The following is a description of a gene set: Mouse Gene Set: GOBP_SODIUM_ION_TRANSMEMBRANE_TRANSPORT A process in which a sodium ion is transported from one side of a membrane to the other by means of some agent such as a transporter or pore. studied in species Mus musculus, and this is the list of marker genes: Scn2a, Wnk1, Kcnq1, Slc24a2, Slc6a19, Slc9a9, Kcnq2, Snta1, Slc6a6, Atp2b4, Slc4a8, Slc9a3, Slc9b2, Slc20a1, Trpm2, Kcnk9, Slc6a12, Cnga3 (NCBI Gene Id 12790), Scn4b, Atp1b1, Slc6a8, Slc24a3, Scn7a, Grin1, Asic3, Slc6a16, Cftr, Slc6a15, Hcn3, Scn3b, Slc6a3, Slc4a4, Slc5a4b, Slc41a1, Mcoln3, Slc34a3, Slc6a20a, Slc9a6, P2rx7, Atp4a, Slc12a3, Atp1a2, Nedd4l, Tesc, Scn4a, Scn1b, Nppa, Commd1, Cav3, Slc5a1, Nherf1, Tpcn2, Slc4a10, Slc5a3, Atp12a, Scn10a, Slc24a1, Slc9a4, Slc9a2, Atp1a3, Fgf13, Scnn1b, Slc5a4a, Slc41a3, Scn11a, Trpm5, Slc8b1, Slmap, Trpv3 (transient receptor potential cation channel, subfamily V, member 3, NCBI Gene Id 68700), Tpcn1, Hcn2, Slc6a1, Neto1, Tescl, Slc24a5, Ptpn3, Slc13a5, Slc6a2, Pcsk9, Slc20a2, Slc28a3, Slc38a4, Scn8a, Kcnk3, Fxyd4, Slc23a1, Slc6a21 (solute carrier family 6 member 21), Slc5a6, Wnk2, Gpd1l (NCBI Gene Id 72363), Asic1, Slc8a3, Slc9a8, Cnksr3, Atp1a1, Slc6a9, Fxyd1, Camk2d (calcium/calmodulin-dependent protein kinase II, delta), Grin2a, Cnnm4, Chp1, Rangrf, Slc6a20b, Bpifa1, Slc13a2, Nalcn, Mcoln1, Slc38a5, Slc17a8, Nos1, Slc4a7, Fxyd7, Slc9a7, Wnk4, Asic2, Slc6a17, Atp1b2, Slc8a2, Fxyd5, Bpifa5, Slc6a7, Asic4, Slc38a2, Slc6a5, Pkd2, Fxyd6, Fgf12, Agrn, Slc9a1, Scn5a, Cnga1, Slc17a7, Trpm4, Slc12a2, Slc6a14, Nedd4, Slc6a11 (NCBI Gene Id 78727), Slc8a1 (solute carrier family 8 (sodium/calcium exchanger), member 1), Hcn4, Fxyd2, Slc12a1, Plcb1, Hcn1, Prss8, Slc34a1, Ank3, Asic5, Gm13629, Scn2b, Scn9a, Slc4a11, Slc5a2, Dmd, Slc9a5, Scn3a, Ano6, Fxyd3, Arf1, Slc17a6, Slc4a5, Scn1a, Pkd2l1, Scnn1g, Atp1b3, Drd4, Slc6a4, Scnn1a, Slc6a18, Tmem168, Slc34a2, Slc38a1, Grp, Slc24a4, Slc9c1, Slc13a1, Ywhah, Atp1a4, Slc4a9, Osr1, Stk39, Slc13a3, Atp4b, Kcnk1, Wnk3, Slc6a13